The following is a description of a gene set: This event has been computationally inferred from an event that has been demonstrated in another species.<p>The inference is based on the homology mapping from PANTHER. Briefly, reactions for which all involved PhysicalEntities (in input, output and catalyst) have a mapped orthologue/paralogue (for complexes at least 75% of components must have a mapping) are inferred to the other species. Reactome Pathway: mitochondrial fatty acid beta-oxidation of saturated fatty acids part of: Mitochondrial Fatty Acid Beta-Oxidation electronically inferred by orthology from the curated human pathway studied in species Mus musculus, and this is the list of marker genes: Hadha, Mecr, Acadvl